Given this list of marker genes MAN2A2, MGAT4B, ST8SIA4, PRKCSH, MAN1C1, ST8SIA6, MAN1A1 (mannosidase alpha class 1A member 1), MGAT4A, MAN2A1, GANAB, GNPTAB, FUT8, ST8SIA2, ST8SIA3, MAN1A2, HEXB, ST8SIA5, ST8SIA1, GNPTG, HEXA, GANC, ENGASE, here is a description of the gene set: species: Homo sapiens Human Gene Set: GOBP_N_GLYCAN_PROCESSING The conversion of N-linked glycan (N = nitrogen) structures from the initially transferred oligosaccharide to a mature form, by the actions of glycosidases and glycosyltransferases. The early processing steps are conserved and play roles in glycoprotein folding and trafficking.